The following is a description of a gene set: Human Gene Set: REACTOME_MEMBRANE_TRAFFICKING Membrane Trafficking studied in species Homo sapiens, and this is the list of marker genes: REPS2, PACSIN3, TSG101, PACSIN1, TUBAL3, SYT8, NBAS, EXOC7 (exocyst complex component 7), PRKAA2, SNX9, DCTN4, SEC22B, RHOBTB3, KDELR2, WASL, RPS27A, EPN2, GRIA1, ARF6, CUX1, ARRB2, PUM1, EXOC6, MAN1A2, TOR1A, NAA35, RAB18, ARF1, VPS51, KIF1B, AP2A1, TBC1D7, ASPSCR1, SH3GL3, GGA1, M6PR, SURF4, CHMP2A, RAB27A, DENND4A, PREB, GJB4, FTL, TMEM115, GJA10, VPS25, DENND2D, YIPF6, IL7R, ARPC2, LNPEP, VPS4B, FTH1, DENND3, ACTB (NCBI Gene Id 60), DENND1C, CHML, LMAN1, DENND2C (NCBI Gene Id 163259), BLOC1S6, RALGAPB, HPS1, VPS36, DYNC1I2, GGA2, GJB7, NAPG, CTSC, COPS3, ARRB1, AREG, CYTH2, COPS2, STAM, ARFIP2, SGIP1, KIFC1, PRKAG3, TBC1D15, RAB11B, EXOC5, ARFGAP2, CLVS2, RAB14 (RAB14, member RAS oncogene family), TRIP11, RAB3IL1, GJC2, TUBB6, RAB3A, COL7A1, HIP1R, MYO5A, SH3GL2, DENND6A, SYT11, SBF1, AKT1, GABARAP, KIF20B, GOLGA1, PPP6R1, CAPZB, GJB5, AGFG1, COG1, YWHAH, AP1M2, ANKRD27, TBC1D17, UBB, RAB30, ARPC5 (NCBI Gene Id 10092), DENND2A, SEC13, TRAPPC4, DNM2 (NCBI Gene Id 338330), RAB4A, HIP1, TRIP10, TBC1D4, PRKAB2, RHOQ, AVP, SYNJ1, SRC, CLTA, AVPR2 (NCBI Gene Id 554), PACSIN2, CHM, RAB21, GOLGA5, AKT2, TRAPPC11, CYTH3, TUBA1A, CTSZ, TBC1D20, VPS37C, TMED7, CAPZA1, CCZ1B, KIAA0319, AMPH (NCBI Gene Id 273), AP2A2, SYTL1, RAB3GAP1, COPS8, RIN2, KIF13B, VAMP4, GDI1, BET1L, EGF, SPTA1, TFRC, PICALM, TUBA4B, GRK2, ARF4, AGTR1, PAFAH1B2, FNBP1, CNIH3, RAC1, CAPZA3, RALGAPA2, ACTR1A, MVB12A, PRKAB1, VPS28, RAB35, VAMP8, ANKRD28, TUBB2A, CTTN (cortactin), ALS2CL (ALS2 C-terminal like), KIF15 (kinesin family member 15), ACTG1, TUBA8, EXOC3, DVL2, KIF18A, TRAPPC2L, SAR1B, TRAPPC6B, RAB36, EPGN, SNF8, KIFAP3, RAB5A, PIK3C2A, DNASE2, LRP2, RIN1, NEDD8, GALNT1, TRAPPC2, AP1B1, SYS1, SEC22C, ULK1 (NCBI Gene Id 8408), COPB1, GJB2, TBC1D14, RAB9A, SNAP23, GJB3, FCHO1, CHMP6, KIF26B, RAB3GAP2, KIF22, CD3G, TRAPPC5, YWHAZ, STX10, RAB13, PLA2G6, DENND6B, TSC1, F8, ACTR10, EXOC4, KIF5A, ARL1, RAB11A, AP4S1, TRAPPC3, GAK, CHMP7 (charged multivesicular body protein 7), TPD52, SCOC, ARPC3 (actin related protein 2/3 complex subunit 3), COPS6, UBQLN2, YWHAG, AP1G2, KIF3C, MIA2, COG7, STX18 (syntaxin 18), NSF, SLC2A4, OPTN, CD55, USP6NL, SPTAN1, SEC23IP, ANK2, AP1S3, STON2 (NCBI Gene Id 85439), UBA52, TRAPPC13, CHMP2B, HBEGF, BICD2 (NCBI Gene Id 23299), WNT5A, TFG, UBC, TOR1B, AP1G1 (NCBI Gene Id 164), YWHAE, SNAPIN, STX5, DNM1, RAB41, STX16, RAB5B, DENND1A, ARF5, KDELR3, COG8, SPTBN5, SH3KBP1 (NCBI Gene Id 94010), VAMP3, KIF18B, VPS54 (VPS54 subunit of GARP complex), VTI1A, AP4M1, GJD2, NAA30, NECAP1, DCTN3, PLA2G4A, COG5, TUBB8B, CLINT1, STX17, FCHO2, AP1S1, RAB33A, COPE, CYTH4, TRAPPC8, TBC1D3, SH3GL1, SEC24B, SLC2A8, DTNBP1, TF, DENND4B, COPG1, AKT3, CNIH1, DCTN1, VAMP7, ARFGAP1, DAB2, RAB7A (RAB7A, member RAS oncogene family), LMAN2L, AP2S1, EXOC8, RAB12, COPB2, ARCN1, CHMP3, CHMP4C, VPS37A, KIFC2, LMAN1L, CFTR, SYT1, RAB1B, ARPC4, KLC1, SLC18A3, TBC1D10A (TBC1 domain family member 10A), AP2B1, CHMP4A, RAB1A, REPS1, RAB38 (NCBI Gene Id 23682), DENND4C, BTC, KLC2, AP4E1, APP, RAB8A, CHMP5, TUBA3C, MAN2A1, COPA (NCBI Gene Id 1314), MAN1A1 (mannosidase alpha class 1A member 1), CLTB, CYTH1, TMED9, MYH9, TMED3, TUBB8, BNIP1, CLTC, RINL, SERPINA1, SNX18, COG6, KIF16B (NCBI Gene Id 79757), AGPAT3, F5, PRKAG1, TUBB3, UBAP1, RGP1, GJA3, SH3D19, SYT2, AP2M1, SNX5, RAB27B, EREG, RABGEF1, HGS, CHMP4B, GORASP1, TBC1D2, SORT1, DNM3, SEC16A, MYO1C, COG2, USE1, KIF25, ARFRP1, AP3B1, CALM1, KIF5B, RIC1, TACR1, MAP1LC3B, KIF1A, RABGAP1, AP1M1 (NCBI Gene Id 8907), ARF3, RAB3IP, TBC1D24, DENND5B, GDI2, PPP6C, SPTBN2, GJA9, SEC16B, TMED10, DCTN6, SYNJ2, TUBB2B, ACBD3, VPS37D, TGFA, DYNC1LI2, TUBA4A, GOLIM4, KIF21A, GJA4, FNBP1L, CAPZA2, KLC3, YWHAB, RAB32, VPS37B, GOLGA2, GJB6, MVB12B, LDLR, SFN, GABARAPL2, MON1A, KIF1C, KLC4, DENND1B, GALNT2, CCZ1, DYNLL1, GJD4, FOLR1, DYNC1H1, RABEPK, SNAP91, RAB33B, KIF2A, KIF4A (NCBI Gene Id 55595), ITSN1, CPD, SEC24C, MAN1C1, AP3S1, ALPP, COG4, TBC1D10C, KIF19, ZW10, SPTBN1, HSPA8, SNAP29, DYNLL2, DYNC1I1, PAFAH1B3, RAB6A, NAPB, KIF11, SYT9, VTA1, SEC31B, AP1S2, PPP6R3, TUBA3D (NCBI Gene Id 150778), VPS52 (NCBI Gene Id 6293), STON1, USO1, COPZ2, ITSN2, MON1B, HPS4, COPS4, TUBA3E, TUBB1, EPS15L1, KIF27, TRAPPC9, RAB9B, TBC1D1, AAK1, GOSR2, DCTN5, TJP1, STXBP3, CNIH2, RAB43, GCC2, NAPA, RAB8B, CENPE, COPZ1, RALA, GOSR1, KDELR1, BLOC1S3, BICD1, MCFD2, CD3D, CLVS1, OCRL, NECAP2, TRAPPC12, BLOC1S4, RAB7B, EGFR, TBC1D16, COG3, PRKAG2, GCC1, NAA38, VPS4A, BET1, SEC22A, DCTN2, BLOC1S1, TUBB4A, SCARB2, TXNDC5, COPG2, STAM2, RAB39B (NCBI Gene Id 7489), PIP5K1C, RAB39A, RAB31, CHRM2, EXOC1, TMF1, GJA8, MIA3, ARPC1A, COPS5, INS, DNAJC6, TUBA1C, KIF3A, C2CD5, TUBB4B, VPS53, PLIN3, CD59, IGF2R, SEC31A, AP4B1, ACTR3, GAPVD1, SCFD1, APOB, FZD4, MAN2A2, STX6, GJC1, ANK1, UBQLN1, GGA3, SEC24A, RAB6B, KIF6, SEC24D, TGOLN2, ARFGAP3, ANK3, GNS, RINT1, KIF2C, CSNK1D, LMAN2, TBC1D13, COPS7B, KIF9, CBL, TPD52L1, RACGAP1, EPS15, GJA1, TRAPPC10, VAMP2, SNX2, COPS7A, GOLGA4 (NCBI Gene Id 2803), TSC2, DENND5A, EXOC2, RAB5C, SBF2, KIF4B, RABEP1, SPTB, EPN1, ACTR2 (NCBI Gene Id 10097), VPS45, TBC1D10B, YWHAQ, STX4, KIF3B, TRAPPC6A, SPTBN4, MYO6, BIN1, TRAPPC1, GBF1, KIF12, KIF26A, TMED2, SEC23A, GJA5, GJB1, CD4, CLTCL1, KIF20A, GPS1, GRK3 (NCBI Gene Id 157), YKT6, KIF21B, ADRB2, KIF2B, GOLGB1, MADD, RIN3, TBC1D8B, TBC1D25, DYNC1LI1 (dynein cytoplasmic 1 light intermediate chain 1), GJD3, GRB2, ALS2, LDLRAP1, TUBA1B, PAFAH1B1, DENND2B, KIF23, RAB10